The following is a description of a gene set: Mouse Gene Set: MIR_1942 from publication Chen Y, Wang X (PMID 31504780) Genes predicted to be targets of miRBase v22 microRNA mmu_miR_1942 in miRDB v6.0 with MirTarget v4 prediction scores > 80 (high confidence targets). species: Mus musculus, and this is the list of marker genes: Slitrk1, Sema6a, Mon1b (NCBI Gene Id 75981), Cd200r3, Oga, Clrn3, Ms4a7, Lamc2, Arhgap36, Kalrn, Orc2 (NCBI Gene Id 98596), Adcy7, Tmem41b (NCBI Gene Id 76341), Obox3, Pcdh17, Qrfpr, Wdr6, Col25a1, Spryd7, Ugt2b34, Asb15, Evi5, Ncapg2, Mfhas1, Fgd4, E030030I06Rik, Rhobtb2, Cxcl14, Ibsp, Pi4k2b, Crhr2, Magi1, Pnrc2, Atxn2, Prnp, Fam76b, Wif1, Spink13, Adgrl3, Rftn2, Nacc1, Stk39 (serine/threonine kinase 39), Cry2, Ccnb1, Cercam, Zfp760, Tomm70a, Pdcd10, Ssbp2, Map7d1, Lnpk, Matr3 (NCBI Gene Id 69967), Jade1, Lrba, 0610040J01Rik, Lrig2, Zbtb39, Derl2, Lgr4, Prpf40a, Or51e2, Rere (NCBI Gene Id 68703), Tox3, Rs1, Trim60, Trmt44, Pcdhb19, Fhod3 (formin homology 2 domain containing 3), Ivd, Rnf146, Akap4, Igf1r, Adcy9, Sall3, Rps6kb1, Mxra8, Dcp2, Tef